Given this list of marker genes PRKRIP1, H2AZ1, BCL9L, HNRNPF, ZNF668, H2BC10, CIRBP, PFKFB3-AS1, RMI1, RCC2-AS1, LAMA5, EIF1, KLF7, MIF, RABL6, MSH3, THBS3-AS1, SS18, ZC3H6, TSHZ3, ISG20L2, ENSG00000245025 (novel transcript, antisense to RHOBTB2), NUDT17, BICRA-AS2, CSNK2B, LSR, CACYBP, ACYP2, PPP1R14B-AS1, NSD1, PFDN2, UPF3A, MALAT1, FAM174C, APOM, H3C6, MCM7, FBXW9, MIR3153, PPP4R3A, SLC39A10, EEF1D, ATP1A1, PRKAG1, C19orf48P, JMJD8, PLK3, H1-10-AS1, THUMPD3-AS1, SNORA64, MEIS1, SNORD35A, ZNF724, RECQL4, ACSL3, SPNS2, CBX3, RABGGTB, PRDX5, MICA, SNORD83B, SCGB3A2, RPL27A, DHRS11, CHEK1 (checkpoint kinase 1), NID2, THOC6, H2BC16P, EPHA1, MAT2A, TTC19, H3C12, RPL15, SECISBP2, ISCA1 (iron-sulfur cluster assembly 1), MFGE8, TTN-AS1, NANP, LINC00869, MLH1, GABPB1, RNU4-2, TSC22D1, PTOV1-AS2, CHERP, XBP1, ZFPM1-AS1, PTMA, BCL2L2-PABPN1, MYL7, EIF5, SNORD83A, LARP7, KIF22, RSRP1, CBL, KPNB1-DT, DPYSL2, UBA2, KDM5B, TUBA1B-AS1, OAZ1, DM1-AS, MLLT10, PDHB, SLC3A2, VPS28, ADCY10P1 (NCBI Gene Id 654172), SCRIB, EFHC1, YY1-DT, GARS1-DT, KLHL35, PYGO2, EPHX3, ERGIC3, MEIS2, ID4 (NCBI Gene Id 3400), DYNLL2, GATD1-DT, MTG1, DDOST, HNRNPU (NCBI Gene Id 3192), SH2B2, SUOX, SP3, EPN1, ZNF33B, RPS11, ZBTB4, ATL2, FMC1-LUC7L2, P2RY11, KDM8, GABPB1-AS1, RNU5E-1, ZNF143, ANP32B, H2AC21, TKFC, NPM1, HCG18 (NCBI Gene Id 414777), RPL14, C12orf57, MDP1 (magnesium dependent phosphatase 1), CHCT1, DYNLL1, ZFHX2, DCP1A, ENSG00000267024, RNVU1-6, EEF1AKMT1, CD24, DNAH10, SNORD13, TWF2, PCGF3, AHCY, LPAR2, RAB1B, NXF1, ATP6V1A, MYL12A, SUMF2 (NCBI Gene Id 25870), CENPJ, CYTH2, COX19, ARID3B, SLFNL1, POLE, VWCE, TTN, C8orf82, TRIOBP, PLPP5, POM121C, ARL6IP1, EIF4A2, RSPH6A, H2AC16, HAND2-AS1, SNORA70, VCP, YTHDF2, RACK1, C11orf98, PPP1R35-AS1, H1-10 (NCBI Gene Id 8971), SSBL4P, H2BC8 (H2B clustered histone 8), GALE, INPP5E, SNORA16A, RPS10, CSNK1G1, ZNF34, MRPL28, QSER1, BOP1, DALRD3, PUM1, GABARAP, MEIS1-AS3, KRTCAP3, GRSF1, SFPQ, SGF29, SLC25A25-AS1, EIF4A1, CHTF8, AKIP1, RNVU1-4, PDSS1, RNVU1-15, VCL, PCGF3-AS1, ACADVL, DAZAP2, MCL1, THOC5, HMGN1, RFX3-DT, MYL6, SF1-DT, RPL22L1, DUT, P4HA1, AGPAT3, UBE2S, ARPC1B, H2AC10P, ACTB, SNORD33, SNORD104, INTS10, RPS6, KCNC3, CSNK1E, GSK3B (NCBI Gene Id 2932), BRD2, H1-5, RND3, ZFAS1, PAN3, PPP6R3, HSP90AA1, FLOT1, SET, SH3D21, MYH6, SRSF3, B3GALT4, IL17RD, NOP14, RPS19, MPV17, H1-3, ADM5, MST1, PKP2 (NCBI Gene Id 93271), ZNF581, OAZ2, GAPDH (NCBI Gene Id 2597), ANKRD37, PTP4A1, MIR4449, H2BC14, H1-4, PPM1A (protein phosphatase, Mg2+/Mn2+ dependent 1A), LINC01521, ZSWIM7, TRIM28, ZFAND5, RAP1GDS1, PIDD1, DUSP6, CHD8, SYAP1, H2BC12, RNVU1-27 (NCBI Gene Id 124904621), GART, MAP3K14-AS1, SLC25A13, ZNF337-AS1, TYMS, ATXN7L3, DDAH2, CCDC34, TOMM6, PCBP4, TMEM39B, MFSD10, MYADM-AS1, GAS5-AS1, PDE4DIPP6, TTI2, CDC42EP3, ARFGAP2, ATP5MC3, ZNF687, SLC35B2, PLEKHG2, PKM, UTP4, UBAC2, SRSF6, DDX59, RN7SL525P, IER3-AS1, SEMA6A, DEPDC5, USP34, ENOX2, RNU5E-4P, SNORD58B, POLG2, PDGFRA, C11orf54, TEAD2, CFL1, PRORSD1P, FLAD1, TRIM37, CD37, ADI1, MTHFS, MSL2, MIR1225, DHX9, LNCPRESS2, C5orf24, MIR302A, MIR7-3HG, GATA4 (NCBI Gene Id 2626), DANCR, H2AC17, SNORD43, SNORD12B, ZNF213-AS1, TERF1, NOP2, YIPF2, DDX3X, INO80, BSG-AS1, DDX39B, DEPDC1B, RRM2, HMGB1, ING1, STK33, MIRLET7I, RPL13, NIT1, GAD1, ZNF775, KCNIP2-AS1, H2AZ2, HMGN2, FLNA, KCTD15, NAP1L1, HSPA5-DT, ZNF121, PHLDA1-DT, EDC4, MYG1, NEK8, TP53I11, DDX54, IER2, MIR4492, GEMIN6, ZC3H4, LINC00114, HDAC4, RPS9, B4GAT1, DYNLRB1, CCDC17, GZMM, MATR3 (matrin 3), PMF1-BGLAP, SNHG25 (small nucleolar RNA host gene 25), ACOT13, SMAD7, DDX17, BAG6, HEXIM1, AGBL2, ARID1B, TRIM65, SNORA50C, RCC2, ARRDC3, CLK3, SPTAN1, MRPL20, ZNF649-AS1 (ZNF649 antisense RNA 1), RFC4, ARHGEF19, RPL5, PMF1, GGA3, TMEM33, KPNB1 (karyopherin subunit beta 1), CCNL1, CRLF3, COX4I1, CBX5, DDIT4, SIRT7, RHOF, YPEL4 (NCBI Gene Id 219539), RBM3, CMTM3, SRSF7, FGFR1, SRRM2, SAE1 (SUMO1 activating enzyme subunit 1), CNOT3 (NCBI Gene Id 9756), GCN1, ZBTB10, SIX5, PTOV1 (PTOV1 extended AT-hook containing adaptor protein), DNAJB14, NFKBIA, DENND2B, SPATS2L, HUS1, CLTC, KDSR-DT (KDSR divergent transcript), SLC15A4, INPP5K, STARD7, CYRIB, SEC31A, H2AC14, BCL2L1, KMT2D, SBNO1-AS1, RNVU1-19, DDB1 (damage specific DNA binding protein 1), ULK3 (NCBI Gene Id 25989), POMZP3, KRBA2, DPY19L3, CCDC106, RNVU1-3, YJU2B, LRCH3, RANGRF, ZC3H10, SMG1P3, UBE2D3, SLF2, HNRNPA2B1, ADAP1, RNH1, MIR6728, PSMC5, KGD4, H2AC13, MIR302D, ONECUT1, RNU2-63P, H3C11, EPM2AIP1, STK26, POM121, SLC25A42, HAND2, LRRC14, EFCAB2, UNG, RAB33B, POU2F1-DT, CSRNP2, B3GALT9, H4C4, POLG, GSK3B-DT, SSU72, REEP3, ZNF587, CLASP1 (cytoplasmic linker associated protein 1), USP1, SFT2D1, TXNIP, MRPS28, ZNF580, IER5L, PRKRA, ASMTL, PNRC1, YWHAZ, BSG, PLEKHN1, NOPCHAP1, YY1, MIR3143 (NCBI Gene Id 100422934), TMEM63A, MRPL12, GPX1, FASN, PRR7-AS1, CHMP2A, FAN1, H2BC21, RPLP2, UBC, RPL13A, TALDO1, PRMT1, ACTG1, LINC01719, TPT1-AS1, BTG1-DT, DYNLL2-DT, TAF10, PATZ1, RPL17, MIDN, HNRNPUL1, RNU5E-6P, ISYNA1, PPM1D, H2BC7, ENSG00000267882, CUL4A, RSRC1, PHPT1, H2BC11, LHB, KIF7, MIR367, MMACHC, SNHG8, LRP2BP, SQSTM1, SNORD118, TMEM170A, PJVK, PGLS-DT, FER, FBXW2 (F-box and WD repeat domain containing 2), STX10, SYNCRIP, MAGED1, HDAC4-AS1, ZNF417, RNU1-1, PNRC1-DT, DTD1, MRPS27, MAZ, RPL4, ALG5, ENSG00000254718, WNK4, ZNF598, CREBZF, EXOSC8, MTG2, VEGFB, MRPS34, SNORD58A, GAS5, USP11, CHMP4A, RAB26, PCIF1, KLF2, CCDC90B-AS1, RNU4-1, RPS10-NUDT3, ZNF367, RBPMS, RNF138, RNU6-826P, GLUL, EOGT-DT, CLP1, SNORD100, RNU5A-8P, SLC35E2B, MIR5087, SNORD116-9, RABEP2, TBXT, ZWILCH, SLC35A2, NR1H2, TPT1, TOB1-AS1, ZFP36L2, MAP3K12, IER5L-AS1, H2AZ1-DT, WNT2, PRRC2A, ESYT1, LINC01089, FAM193B, SFXN5, SRA1, NRAS (NCBI Gene Id 4893), BOLA1, CFAP68, AKAP8, ZNF213, SPRY2, DSP-AS1, MYO1C, CAPNS1, CDC42EP2, BHLHE40, ZZZ3, WBP4, SETD5, MAT2B, TMEM179B, ZBTB9, NAT10, RBM25, CDCA5, CSNK1D, LSM5, NT5C, MFSD11, TIGD5 (tigger transposable element derived 5), C18orf32, SELENOW, HSD17B1, MIR130AHG, ARHGEF40, PSMD12, LINC00881, LRP6, IAH1 (isoamyl acetate hydrolyzing esterase 1 (putative)), NRAV, GPX4, SNORA57 (small nucleolar RNA, H/ACA box 57), ZFP36L1, POLR2C, NAA50, STAG3L3, ENSG00000263011, ESRG, USP32, RCOR3, SNORD34, TM7SF2, CYB5R2, TCAIM, ZNF398, USP34-DT, AVIL, ZNF653, NFE2L3, PNRC2, PABPC1L, H2BC18, SIL1, EEF1A1, BRICD5, OGA, RPL10, AURKAIP1, SRCAP, HERC1, USF2, LUC7L3, PXN, DHFR, ELF2, PGLS, RNU7-1, ELL3, RAB24 (RAB24, member RAS oncogene family), SH2B1, PYGO2-AS1, PNISR, CHD2, RABGEF1, PACS1, DVL2, SON, REX1BD, BUB1, H2BC17, MIB2, NOL7, CERS5, WDR18, MIR3190, HNRNPH1, BICRA (BRD4 interacting chromatin remodeling complex associated protein), ZDHHC14, ZFPL1, LEAP2, PSMG1, KCTD7, CDC6, SLC30A9, BCL2L2, LNPPS, PUM2, GRB2, H2AC6, PRR4, AXIN2, EOGT, H2AC12, TWF2-DT, USPL1, PFKP, PRR7, PNKP, SERPINB9, COX20, COMMD5, H4C8, FAM13B, FAM117B, PHLDB1, SELENOOLP, TAF1D, METTL25B, RNVU1-30, SNORD68, CREM, SNORA78, H2AC7, SNORA10, HNRNPA1, PCNT, NOP56, FTSJ3, ZNF143-AS1, MBD1, JAKMIP1-DT, H3C10, CAPN15, TDP2, DNAJA2 (NCBI Gene Id 9237), GDPD3, BCLAF1, RNF225, VPS35 (VPS35 retromer complex component), COPS3, PRPF31, STMN1, TLCD1, RPS14, NCL, TYMSOS, RPL3, TCAF1, DYRK1B, ZNF655, PHACTR4, ALDOA, SLC25A36, H2AC8, FAM200A, RPS15, RPL17-C18orf32, CXorf38, CCAR2, BMP2K, TAF15, TTC4, HNRNPC, H2AC20, RCC1, VWA7, MTRF1L, DNASE1, GTPBP1, ZCWPW1, PPFIA2, PKD1, PHLDA1 (pleckstrin homology like domain family A member 1), FOCAD-AS1, KDSR, KPNA2, VDAC2, ORC6, ZNF292, TSSC4, ACTN4, TRIM39, ELF1, SCN1B, EME2, ATN1, EIF4A3, XRN1, NKIRAS1, H4C1, HUWE1, METTL23, RFX3, PSIP1, SNORD95, MIR302C, DNM1, NUP54, RUSC1 (NCBI Gene Id 23623), ENSG00000261840 (NCBI Gene Id 730183), WDR1, NPM3, MIR4512, SGSM3, ACIN1, TNFRSF12A, DUT-AS1, MIR3187, LYRM2, MAP3K11 (mitogen-activated protein kinase kinase kinase 11), RPS6KB2, USP45, KAT8, LINC01126, SYNRG, RPL26, EPC1-AS1, ZNF23, ING5, BTF3, PHYKPL, LETM2, PRKAR1A, RNU5A-1, SNAPC5, HIF1A, THBS3, H3C4, FPGS, UQCRC1, ZFYVE21, DERL3 (NCBI Gene Id 91319), PKMYT1, PRELID1, ENSG00000228395, SRRM2-AS1, POLR2A, RNVU1-21, SNORD82, CDH24, C14orf93, MTRFR, CHASERR, HSD17B14, FMC1, CSKMT, SNHG12, MIR4530, GPC4, RNU12, CCT8, FDXACB1, H2BC4, WDR27, NEU3, SMAD6, ZDHHC8, KCNH2, SETD6, TPI1, SNORA26, SMIM10L1, POLDIP3, FTX, STUB1, KRBOX5, FAM20A, IMPDH2, DECR2, C6orf136, MSH4, EIF5A, SUMO1, JMJD6, EPC2, RPS3A, KLF2-DT, HEXIM2, ARPC1A, PSMA1, EPC1-AS2, SMIM26, ERCC1, REEP4, PDF, DIDO1, H2AZ2-DT, PAN3-AS1, BTF3-DT, FUT11, POU2F1, MYH9, HES6, CHPF2, TMSB4X, B4GAT1-DT, MRM1, THAP3, RPS15A, CACNG8, CD68, CCND1, TNFRSF25 (TNF receptor superfamily member 25), RPS2, TRAF4, ENSG00000272008, AP4M1, SSBP3, RNVU1-28, IST1, JSRP1, ZNF821, SF1, H2BC13, GEMIN8P4, SBF1, H3-3B, RNU11, SLC38A2, RNA5SP155, GFPT2, VEZF1, PCBP1-AS1, SRSF2, CNP, BBS4, DNAJA2-DT, C16orf95-DT, SPATA32, C16orf95 (NCBI Gene Id 100508034), RBL1, PANX1, EXOSC6, FBXL14, HMGA1, RUFY1, ANKRD13D, MRPL53, CLDND2, PKD1-AS1, FAM83E, HSPA5, VARS2, PRKD2, HERPUD1, MTA1, SAMD1, PSMB10, MIR3912, DCP1B (decapping mRNA 1B), AMDHD2, GRWD1, SNHG9, GPANK1, HNRNPH3, TPM1, SNORA24, UFSP1, PFKFB3, SMG1P2, EMC8, APEH, USP44, ZNF577, MIR5188 (microRNA 5188), ARSD, MPHOSPH9, NOTCH1, TERB1, CSK (C-terminal Src kinase), KLC1, ANKRD12, GAREM2, SLC26A6, SNORD12, MYADM, ZNF497-AS1 (NCBI Gene Id 105372483), DNAJC9-AS1, AMZ2, DKKL1, POMT1, H2AC11, OIP5-AS1, GAL3ST4, CLTA, PCID2, USP22, RNVU1-22, HIGD2B, SPACA6, NINL, PITPNA-AS1, GPATCH4, TUFM, ZBTB37, TPM4, OVCA2, PTOV1-AS1, here is a description of the gene set: Human Gene Set: SETD7_TARGET_GENES species: Homo sapiens from publication Yevshin I, Sharipov R, Kolmykov S, Kondrakhin Y, Kolpakov F (PMID 30445619) Genes containing one or more binding sites for (SETD7) in their promoter regions (TSS -1000,+100 bp) as identified by GTRD version 20.06 ChIP-seq harmonization.